Given this list of marker genes CDK2, E2F8, ZNF385A, CCNE1, CCNA1, CDKN1B, ARID3A, CCNE2 (cyclin E2), PCBP4, TP53, E2F7, E2F1, CCNA2, CDKN1A, here is a description of the gene set: part of: TP53 Regulates Transcription of Cell Cycle Genes The most prominent TP53 target involved in G1 arrest is the inhibitor of cyclin-dependent kinases CDKN1A (p21). CDKN1A is one of the earliest genes induced by TP53. CDKN1A binds and inactivates CDK2 in complex with cyclin A (CCNA) or E (CCNE), thus preventing G1/S transition. Considering its impact on the cell cycle outcome, CDKN1A expression levels are tightly regulated. For instance, under prolonged stress, TP53 can induce the transcription of an RNA binding protein PCBP4, which can bind and destabilize CDKN1A mRNA, thus alleviating G1 arrest and directing the affected cell towards G2 arrest and, possibly, apoptosis. Expression of E2F7 is directly induced by TP53. E2F7 contributes to G1 cell cycle arrest by repressing transcription of E2F1, a transcription factor that promotes expression of many genes needed for G1/S transition. ARID3A is a direct transcriptional target of TP53 that may promote G1 arrest by cooperating with TP53 in induction of CDKN1A transcription. However, ARID3A may also promote G1/S transition by stimulating transcriptional activity of E2F1.<p>TP53 has co-factors that are key determinants of transcriptional selectivity within the p53 network. For instance, the zinc finger transcription factor ZNF385A (HZF) is a direct transcriptional target of TP53 that can form a complex with TP53 and facilitate TP53-mediated induction of CDKN1A, strongly favouring cell cycle arrest over apoptosis. studied in species Homo sapiens Reactome Pathway: TP53 Regulates Transcription of Genes Involved in G1 Cell Cycle Arrest